The following is a description of a gene set: Human Gene Set: GSE22601_DOUBLE_NEGATIVE_VS_CD8_SINGLE_POSITIVE_THYMOCYTE_DN species: Homo sapiens Genes down-regulated in thymocytes: double negative versus CD8 single positive. T cells develop from progenitors that migrate from the bone marrow into the thymus. Thymocytes are subdivided roughly as being double negative (DN), double positive (DP), or single positive (SP), based on the expression of the CD4 and CD8 coreceptors. The DN stage is heterogeneous and can be subdivided into four distinct subsets in mice based on the expression of CD44 and CD25. In human, three distinct DN stages can be recognized: a CD34+CD38−CD1a− stage that represents the most immature thymic subset and the consecutive CD34+CD38+CD1a− and CD34+CD38+CD1a+ stages. Human DN thymocytes mature via an immature single positive (ISP CD4+) and a DP stage into CD4+ or CD8+ SP T cells that express functional T cell receptors (TCR) and that exit the thymus. In this study, gene expression was measured in each of these nine stages. from publication Dik WA, Pike-Overzet K, Weerkamp F, de Ridder D, de Haas EF, Baert MR, van der Spek P, Koster EE, Reinders MJ, van Dongen JJ, Langerak AW, Staal FJ (PMID 15928199), and this is the list of marker genes: RPS6, ZNF629 (zinc finger protein 629), SLC45A4, PRKAG2, RAPGEF4 (NCBI Gene Id 11069), OR4K5, SPMIP8, PSEN2, OR2W5P, SLC5A7, TMEM14A, SNORD6, SEC14L1, OPN5, ZNF85, TSPAN13, RAB39B, PPP1R13L, ZBTB34, RHBDF1, SNX5, TOP1MT, PDC, OR6C74, TBC1D24, UPK3B, TBC1D4, OR10Q1, SH3YL1, POU2F2, SLC6A20, USP20, SPATA20, PRKCD, SSPOP, PBK (NCBI Gene Id 55886), TCAP, TMEM200A, OR12D2, SEPTIN14, PLCL2, PSG3 (pregnancy specific beta-1-glycoprotein 3), TMEM212, PRUNE1, TAMM41, OR11H6, SPOCD1, XRN1, RP1, OR6C3, TMEM81, SLC35G5, ZNF841, ZNF879, RBPMS, SCUBE3, CCN5, SLC44A3, PKDCC, OR4F15, ZNF106, TIGD4, TBXAS1, PELI3, SMAD5-AS1, PDHA2, SETD5, SPPL3, SERPINE1, ZSCAN12, TLR5, TDRD12, POU6F2, ZRSR2P1, SMTNL2, SMARCA4, PIK3C2B, RXRG, TKT, SNORA54, SNORD115-41, PDE2A, SPATS2 (spermatogenesis associated serine rich 2), SLC26A8, SNORA14B, OR52A1, UCN3, RD3, SH3TC2, XAGE3, OR1L1, RAB3GAP1, SPACA4, MAP3K19, PEX19, SRSF11, SUSD2, TNFRSF19, OSBPL11, TMEM105, PARP4, ZNF484, REC8, PDLIM3, VWC2L, TYW1B, TMEM231, SLC29A2, TGFBI, VWF, TUT4, VPREB3, RHBDF2, PRSS30P, ZNF527, SFTPD, ZNF672, PROX1, SIRT3, RBP2, SP1, SFMBT2, SESTD1, TBCEL, TSEN2, PNLIPRP3, PHTF1, ZNF648, ZNF749, SNX19, TRA2A, POLR2A, TIMP3, RIF1, TERC, SLC26A3, TMEM176A, TGFB3, SNORD53, PPP1R13B, SCARNA6, SNORD115-40, RAMP3, PFDN5, PIP4P1, PWWP2A, TRAV8-3, PTGER3, PRSS27, TACSTD2, PNCK, OR52E8, SMC4, SLC35A1, PCDHB14, RELT, RNASET2, PCID2, SLC22A20P, ZNF808, PDAP1, PHF21B, OXNAD1, SUV39H1, SCN1A, PROCR (NCBI Gene Id 10544), SETDB2, ZNF628, SUN2, P2RX3, SATB1, ZNF714 (zinc finger protein 714), SLC17A6, PDZD7 (NCBI Gene Id 79955), SLC5A8 (solute carrier family 5 member 8), PLBD1, SNORD115-44, PBX1, RIBC1, TAS2R60, SLC25A45, VCL, ZNF91, PPIF, USP42, TMEM100, PPP3R2, ZNF112, TOX2, ZAR1L, ZBED5, TIMM8B, SCN7A, GATD1, TMEM59L, ZNF781, PCSK2, TCF12